The following is a description of a gene set: Mouse Gene Set: GOBP_POSITIVE_REGULATION_OF_SMOOTH_MUSCLE_CONTRACTION Any process that activates or increases the frequency, rate or extent of smooth muscle contraction. species: Mus musculus, and this is the list of marker genes: Srf, Adra2b, Oxtr, Tbxa2r, Edn3, Ghsr, Pawr, Abat, Oxt, Edn2, Ptafr, Itga2, Lck, Spx, Gper1, Npnt, F2r, Adra1a (NCBI Gene Id 11549), Tacr2, Rhoa, Tacr3, Cttn, Sphk1, Ptger3, Ptgs1, Ghrl, Prok2, Tacr1, Edn1, Ada, Kit, Ptgs2, Myocd, Npy2r, Chrm3, Nmu